The following is a description of a gene set: An appetite for and the persistent ingestion of non-food substances such as clay. In order to diagnose pica, this behavior must have persisted over a period of at least one month. studied in species Homo sapiens Human Gene Set: HP_PICA Pica, and this is the list of marker genes: CDK13, ASH1L, ZSWIM6, CHD8 (NCBI Gene Id 64329, chromodomain helicase DNA binding protein 8), ELP2, DHPS, RNU4-2, TAF4, PGM2L1